Given this list of marker genes TSPAN12, BEST1, EFEMP1, CFH, CFI, NDP, CTNNB1, FZD4, LRP5, ZNF408, here is a description of the gene set: Subretinal fluid Edema/fluid accumulating between the retinal pigment epithelium and Bruch's membrane. species: Homo sapiens Human Gene Set: HP_SUBRETINAL_FLUID